Given this list of marker genes Arg2, H4c11, Kbtbd13, Oxa1l, Apeh, Eef2, C1galt1, mt-Nd4l (NCBI Gene Id 17720), Dctn1, Mfge8, Top2a, Spcs2, Ctr9, Rpl36a, Rnf168, H2bc11, Usp42, Gata3, Aurkaip1, Rab27b, Apoa5, Asb16, Vdac3, Mrpl53, H2ac1, Psmd12, Ubb, Atp5pd, Thy1, Fbxl21, Gcg, Aaas, B3galnt2, Cog7, Ufd1, Hsp90b1, Cbx8, Adamtsl5, Ring1, Ndc1, Usp47, Usp17la, Rab4a (RAB4A, member RAS oncogene family), Npm1, Nup42, Nsmce3, Cul4b, Rab8a, Tomm20, Ppp6c, Phc1, N6amt1 (NCBI Gene Id 67768), Apol9b, Spsb3, Gng11, Fbxl5, Gspt2, Psca, St8sia4, Hdac4, Fbxl13, Mrpl33, Psmc2, Cct3, Fbxl19, Eef1akmt1, Galnt9, Men1, Rab6a (RAB6A, member RAS oncogene family), Tgfa, Acad8, Rab35, Senp2 (NCBI Gene Id 75826), Rpl37, Bmp4, Mrps16, Rps24, Brca1, Ube2n, Npl, Gzmn, Gata6, Trappc9, Fkbp8, Actr1a, Leo1, Mrpl32, Pcgf2, Klhdc10, Ly6d, Galnt14, Nup58, Fbxo40, Rps7, Pdha1, Psmd1, Atp5po, Uchl3, Rcn1, Adra2c, Thsd4, Rpl27a, Mrtfa, Eif3e, Rnf7, Usp22, Exoc2, Sec11c, Amfr, Cox5a, Hdac7, Rpl29, Ktn1, Rpl11, Usp3, Vcp, Rpl3, Pomk, Fbxw9, Meltf, Rpl23a, Btbd6, Sema5b, Pigyl, H4c9, Vcpkmt (valosin containing protein lysine (K) methyltransferase), Gcnt3, Fut10, St6galnac2, Muc5b, Mepe, F7, Wdr20, Dag1, Nup93, Klhl13, Plet1, Eif2b4, Cct5, H2bc12, Apoe, U2af2, Apol8, Rtn4rl2 (reticulon 4 receptor-like 2), Psme2, H2ac4, Neu1, Rab39, Mrpl4, Mrpl27, Alg6, Apol11b, Rpl39l, Scmh1, Pigt (phosphatidylinositol glycan anchor biosynthesis, class T), Lypd3 (Ly6/Plaur domain containing 3), H2ac12, Fstl3, Ttll9, Psmb9, Riox1, Cops6, Rnf40, Tuba1b, Sec16b, Spp2, Rab5c, Fbxl16, Msrb3, Senp8, Fktn, Lmo7 (LIM domain only 7), Nfrkb, Seh1l, Nup205, Pigg, Neu2, Rps12, Psmb4, Rccd1, Tmed3, Usp4 (ubiquitin specific peptidase 4 (proto-oncogene)), Usp12 (ubiquitin specific peptidase 12), Txn1, Fam20a, Fbxo10, Psma1, Neu3, Ar, Dph6, Adamts4, Galnt15, Muc1, Uba1, Ace, Timp1, Arsa, Rab33a (RAB33A, member RAS oncogene family), Man1a, Thrb, Dph2, Ins1 (NCBI Gene Id 16333), Adamtsl2, Nudt14, Ube2d1, Ptp4a2, Nr1i2, Rpl26, Arsi, Ceacam2, Pigp, H2ac25, Rps4x, P4hb, Rae1, Commd10, Dcun1d1, Fbxl8 (NCBI Gene Id 50788), Rps13, Sumf1, Ppa1, Nfkb2, Sec31a, Nsmce1, Ceacam1, H4c3, Ank1, Pomt2, Dcaf6, Usp29, Trp53, Nup210, Rps9, Rab18, Kctd7, Sptbn2, Ttll12, Acot2, Amelx, Psmb10, Mrpl34, Pigw, Tuba1a, Nans (NCBI Gene Id 94181), Alg1, Usp21, Apol7b, Rab34, Mrps21, Tmem132a, Ankrd9, H2bc1, Galnt4, Exoc1, Rad21, H2ac10, Spp1, Psmb5, Rpl18a, Ckap4, Eif2s3x, Sec31b, Pofut2, Fau, Yy1, Negr1, Hspd1, Arrb2, Rpl9, St6galnac3, Enpep, Calm1, Spaca4, Bet1, Scg2, Smurf2, Cga, Eif3i, Rps3a1, Mrpl55, Usp5, Lypd2, Psg22, Bdh1, H2ac23, Tuba1c, Gngt1, H2ac22, Inhbc, Acadsb, Bche, Eif3b, H2ac24, Slc30a8, Pcna, Folr2, Crppa, Dld, Dcaf13, Sftpb, Asgr1, Usp28, Rnf123, Mrpl22, Stam, Mrpl15, Mxra8, H2ac11, Gfus, Piga (NCBI Gene Id 18700), Rab37, Fbxo27, Gfpt2, Ndufa2, Trmt112, Apoa1, Ube2w, Rpl12, Jmjd7, Babam1, Mief1, Man1c1, Rps19, Mrpl36, Gmppa, Srp54a, Gas6, Tnks2, Sec24b, Mrpl47, Rnf128, Lypd4, Ino80c, Inhba, Trp53bp1, Psmg1, Slc25a5, Mrps6, Mrpl54, Alg12, Asxl2, Neu4, Fbxw4, Vhl, Psme1, Serpina10, Vdac1, Adamts18, Commd4, Cct6a, Vnn1, Asb11, Ttll2, Eif1ax, Fshb, Dpp4, Ace2, Fem1b, Ulbp1, Pabpc1, Eif3f, Copb2, Mrpl16, Rps11, Kdelr3, Proz, Commd1, H2ac8, Proc, Commd5, St3gal4, Mrpl3, Cdh2, Muc13, Notum, Mrpl35, Actr10, Rpl27, Sumo1, Fh1, Sftpd, Eif3d, Spsb2, Plaur, Dnajc24, Acot3, Usp25, Chrdl1, Wfs1, Eci1, Dcaf4, Sprn, Sec24d, H2bc22, Psmb7, Mmrn1, Pigl, Folr1, Cd52, Rplp2, Dcaf10, Scfd1, Adamts15, Tnfaip3, Birc3, Socs2, Cd55, Fgg, Lman2l, H4c14, Kdelr2, St3gal3, Psmc6, Rgs9, Rbbp7, Pomt1, Gnb5 (guanine nucleotide binding protein (G protein), beta 5), Ly6k, Rab39b, Ube2r2, B3gntl1, Chst4, Ube2g1, Pros1, Kng2, Ing2, Csnk2b, H4c2, Prss41 (serine protease 41), Mrpl28 (NCBI Gene Id 68611), Cfp, Fbxl14, Asb18, Aplp2, Mrps12, St8sia5, Gnpnat1, Axin1, Mgat1, Taf9b, Copg2, Fbxo30, Tuba8 (tubulin, alpha 8), Glt28d2, Slc35c1, Emid1, Pex13, Cyld, Rab1b, Htra2, Ube2c (NCBI Gene Id 68612), Tmed9, Gng7, Psmb6, Mbd1, Ces1d (carboxylesterase 1D), Igfbp3, Fstl1, Uqcrc2, Sts (NCBI Gene Id 20905), Eif5b, Usp26, Cish, Mrpl40, Cbx4, Adamts12, Rab1a, Grp, Calr, Trf, Fut8, Josd1, Ins2, Ino80b, Psmc5, Lgals1, Pcsk1, Psma2 (proteasome subunit alpha 2), St8sia3, Apol9a, Rab44, Nup155, Fbxl7, Mrpl58, Ctsg, Etfbkmt, Muc15, Ly6e, Il6 (interleukin 6), Trappc5, Foxk1, Rab11a, Ep300, Nr5a1, Adamts13, Ube2e3, H2ac19, Usp17lc, Rps8, Cpm, Pigx (NCBI Gene Id 72084), Rpl7, Jmjd4 (NCBI Gene Id 194952), Tubb6, H2ac6, Copb1, Eid3, Dynll1, Bmi1, St3gal5, Ddb1, Gng8, Mrpl2, H2ac13, Mrrf, F2, Cdk1, Psmd7, Apol7e, Copg1, Rab36, Tubb2b, Myc, Rraga, Rab3b, Mrpl21, Psmc4, Muc20, Ech1, Prkdc, Ccdc22, Dtl, Mtrf1, Zfp131, Park7, Asb9 (ankyrin repeat and SOCS box-containing 9), Ube2e1, Brcc3, Axin2, Slc35a4, Tectb, Lman1, St8sia2, St6gal2, Usp37, Apol10b, Otoa, Rps25, Idh2, Reck, Pomc, Gpc3, Sec24a, Nsmce2, Clpx, Mgat5b, B3gnt6 (UDP-GlcNAc:betaGal beta-1,3-N-acetylglucosaminyltransferase 6), Rpl4, Prkn, Ggcx, H4c18, Tubal3, Psg29, Mta1, Rab9b, Fech, Rpl14, Nup54, Smc6, Atp6ap2, Fbxo17, Rgs6, Gan, Mrpl14, Lipt2, Nrn1, Tuba4a, Kdelr1, Smad7, Mdc1, Uso1, Mrpl11, Atp5pf, H2bc15, Ano8, Galnt12, Cd109, Galnt1, Vdac2, Cst3, Ccna1, Cpa3, Mrpl51, Ctsc, Ndufv3, Lrr1, Aldh1b1, Arf1, Malsu1, Cbx2, Fbxo31, Dcun1d5, Ascc3, B4galnt2, Psmc1, H2bc7, Nfkbia, Eif4ebp1, Rps18, Tab1, Sin3a, Hcfc1, Rps17, Gnb3, Hnrnpk, Asb17, Eif3k, F8, Traf3, Adora2a, Psma6, Rpl13, Eef1akmt2, Psmd13, Suds3, H4c4, Kctd6, H4c6, mt-Atp8, Manea, Cntn3, Alpl, Rpl36al, Klhl11, B4galt6, Spcs3, Atp5f1b, Mrpl23, Arf5, Lypd5, Igf2, Cct7, Psma4, Cul4a, Rela (NCBI Gene Id 19697), Apoa2, Nup133, Gng3, Mitf, Psma7, Msln, Fbxl3, Col7a1, Cog8, Ly6h, P2ry2, Mysm1, Gcnt7, Mrpl13, Man2a1, Foxo4, Usp19, Lman1l, Fuom, Vcpip1, Btbd1, Fkrp, Dhps, Fbxl15, Prss23 (NCBI Gene Id 76453), Ubd, Pigf, Serpind1, Rpl19, Mrps33, Napsa, Tmed10, Arsg, Derl1, B3gnt8, Ttll3, Ptrh2, Rab3a, H2bc3, Smad3, Vdr, Rab32, Vgf, Rpl37rt, Nrn1l, Arsj, Afg3l2, H2ac15, Mrps26, Fgf23, Mrpl57, H4c8, Mrpl52, Alg8, Eif3j2, Ahsg (alpha-2-HS-glycoprotein), Rpl3l, Rpa1, Nsmce4a, Ffar1, Psma5, Rabggtb, Cnih2, Ctsd, Epas1, Cct8, Rpl39, Mrps7, Hrc, Asb14, Blm, Dctn6, F9 (coagulation factor IX), Sptbn4, Rgs7, Msrb2, Klhl5, Rpl24, Mgat4c, Josd2, Rps2, Asgr2, Pomp, Apob, Penk, Smdt1, Foxl2, Rps20, Daxx, Eef2kmt, Rab8b, Sbspon, Dolk, Nedd8, Rabggta, Spon1 (NCBI Gene Id 233744), Matn3, H2ac7, Rab30 (NCBI Gene Id 75985), Hif3a, Xpc, Prkaca, Rab10 (RAB10, member RAS oncogene family), Psme3, Asb8 (ankyrin repeat and SOCS box-containing 8), Psmc3, Ttll7, Amtn, Lonp1, Mrps18c, Rps6, Rpl6, Enam, Nr1h4, Rab38, Mdga2, Nsf, Gip, Rab21, H2bc8, Srp9, Smc3, Pias4, H2ac20, Dnmt1, Rps15, Rps23, Adamts1, Psma3, Glud1, Slc30a5, Camkmt, Rchy1, Gnat3, Hic1, A4gnt, Nr3c1, Eef1a1, Ifih1, L3mbtl2, Gngt2, Tfpt, Tnip3, Igfbp7, Psmb11, Mrpl17, Cmas, Ndufa13, Muc17, Asxl1, Gng4, Apol10a, Amdhd2, Otub1, Alpi, Cct2, Ube2s, Pigs, Usp17ld, Gng5, Psmg4, Drg2, Engase, Aldh2, Fdx1, Rigi, Kdm8, Dlat, Tnip1, Spcs1, Gng10, Pex5, Asb12, Rnf152, Rab40b (NCBI Gene Id 217371), Kbtbd8, Mdga1, Pigb, Rwdd2b, Esr1, Nanp, Satb2, C3, Afp, Dcaf5, H4c1, Pigz, Mrpl1, H2bc9, Cnih3, Dnmt3b, Exoc7 (NCBI Gene Id 53413), Clpp, Eif3g, Fpgt, Rpl38, Hif1a, Sumf2, Rpl18, Scg3 (secretogranin III), Lypd8, Areg, Prmt3, Fbxo9, Ube2k, Taf10, Gnb2, Fbxl4, Thbs2, Cul1, Commd7, Eef1g, Oxct1, mt-Cytb, Ly6g6c, Rpl37a, Alb, St6galnac1, Zfp598, Rps28, Tfam, Otud7a, Nop58, Wsb2, Adamtsl1, Dlst, Fem1a, Fn3krp, H2bc13, Usp17lb, Rps27a, Mul1, Mrps35, Kdm1b (lysine (K)-specific demethylase 1B), Wsb1, Tubb4b, Arcn1, Chgb, Inhbb, Galntl5, Nup85, Rab40c, Mdh2, Snx3, Otud3, Rps26, Chst8, Adamtsl4, Golga2, Apol7a, Bglap2, Trim27, Mrps36, St6galnac4, Rps10, Pigv, Becn1, Gp2, Tdg, Nagk, Gmppb, Rps27l, Tnc, B3gnt3, St6galnac6 (ST6 (alpha-N-acetyl-neuraminyl-2,3-beta-galactosyl-1,3)-N-acetylgalactosaminide alpha-2,6-sialyltransferase 6), Lep, mt-Nd6, H4c17, Klhl41, Ctsh, Smad1, Rad52, Mrps17, Nlrp3, Asb5, Adra2a, Fut11, Arfgap2, Cct6b, Ppa2, Gh, Psmd4, Pex12, Rpl15, Dync1li2, Gna14, Eif4a1, Asb10, Lmcd1, Ccnf, Rab7, Cdc34, Ncoa1, Socs3, Acot5, Gpihbp1, Cma1, F10, mt-Nd3, Prkcsh, Tuba3b, Rara, St3gal2, Bard1, Il33, Wdr48, Ndufs3, Psmd6, Tubb4a, Aurkb, Gorasp1, Sparcl1, Rab26, Usp44, H4c12, Rps5, Fbxo32, Renbp (renin binding protein), Rab19 (NCBI Gene Id 19331), C4b, Eif4a2, Psmb8, Rnf146, Stag1 (STAG1 cohesin complex component), B3gnt9, here is a description of the gene set: Reactome Pathway: Metabolism of proteins species: Mus musculus This event has been computationally inferred from an event that has been demonstrated in another species.<p>The inference is based on the homology mapping from PANTHER. Briefly, reactions for which all involved PhysicalEntities (in input, output and catalyst) have a mapped orthologue/paralogue (for complexes at least 75% of components must have a mapping) are inferred to the other species. electronically inferred by orthology from the curated human pathway